The following is a description of a gene set: Human Gene Set: OUILLETTE_CLL_13Q14_DELETION_UP Genes up-regulated in chronic lymphocytic leukemia (CLL) samples bearing deletions in the 13q14 region. studied in species Homo sapiens from publication Ouillette P, Erba H, Kujawski L, Kaminski M, Shedden K, Malek SN (PMID 18281475) Chronic lymphocytic leukemia (CLL) is a biologically heterogeneous illness with a variable clinical course. Loss of chromosomal material on chromosome 13 at cytoband 13q14 is the most frequent genetic abnormality in CLL, but the molecular aberrations underlying del13q14 in CLL remain incompletely characterized. We analyzed 171 CLL cases for loss of heterozygosity and subchromosomal copy loss on chromosome 13 in DNA from fluorescence-activated cell sorting-sorted CD19(+) cells and paired buccal cells using the Affymetrix XbaI 50k SNP array platform. The resulting high-resolution genomic maps, together with array-based measurements of expression levels of RNA in CLL cases with and without del13q14 and quantitative PCR-based expression analysis of selected genes, support the following conclusions: (a) del13q14 is heterogeneous and composed of multiple subtypes, with deletion of Rb or the miR15a/miR16 loci serving as anatomic landmarks, respectively; (b) del13q14 type Ia deletions are relatively uniform in length and extend from breakpoints close to the miR15a/miR16 cluster to a newly identified telomeric breakpoint cluster at the approximately 50.2 to 50.5 Mb physical position; (c) LATS2 RNA levels are approximately 2.6-fold to 2.8-fold lower in cases with del13q14 type I that do not delete Rb, as opposed to del13q14 type II or all other CLL cases; (d) PHLPP RNA is absent in approximately 50% of CLL cases with del13q14; and (e) approximately 15% of CLL cases display marked reductions in miR15a/miR16 expression that are often but not invariably associated with bi-allelic miR15a/miR16 loss. These data should aid future investigations into biological differences imparted on CLL by different del13q14 subtypes., and this is the list of marker genes: ATAD2, RPL31, SLC9A7, BBIP1 (NCBI Gene Id 92482), FRS2, PHTF2, BBX, UBE2Q1, RAB1A, NAT16, ZNF24, EAF2 (NCBI Gene Id 55840), ZNF546, CYB5A, CEP250, ZBTB44, USP37, TGOLN2, GLIPR1, C1orf52, ENSG00000284634, ARL10, SGK3, USP6NL, ATP5MF, KDM4B, ZBTB20, ZNF577, SPTBN2, TRIM38 (tripartite motif containing 38), ASPHD1, VRK3, GTPBP4, KRR1 (KRR1 small subunit processome component homolog), GINS4, LONRF3, CASP1, ZNF597, SLC50A1, PLRG1, TPD52, VCPIP1, CLPB, ZNF548, TIPIN, ZNF221, EXTL1, WDR59, LARGE2, RUFY3, ZNF572, MED6, FANCI, INCENP (NCBI Gene Id 56989), RHOXF2, PPTC7, SPNS1, ADRA1A, SPACA3, CTC1 (NCBI Gene Id 80169), UQCC2, ZIK1, FAM193A, CDC27 (cell division cycle 27), PTPRO, RASGEF1B, WASHC4, ADAM17, ARHGAP20, NDRG2, KLHL5, IMPA1, MAPK1, MACROD2, PAFAH1B1, CENPJ, ZNF226